The following is a description of a gene set: Any process that modulates the frequency, rate or extent of a process involved in the formation, arrangement of constituent parts, or disassembly of a chromosome. species: Mus musculus Mouse Gene Set: GOBP_REGULATION_OF_CHROMOSOME_ORGANIZATION, and this is the list of marker genes: Tal1, Spdl1, Smarca4, Mcph1, Mcrs1, Plk1, Myc, Baz1b, Ncapg, Prkcq, Cdc27, Rmi2, Becn1, Nabp2, Usp44, Pkib, Nat10, Mre11a, Ube2u, Smc2, Ncaph2, Map3k4, Smarcd2, Rnf4 (NCBI Gene Id 19822), Ino80d, Smarcc1, Tex14, Mapkapk5, Ankrd66, Dhx36, Setmar, Tacc3, Ino80b, Potefam3b, Anapc5, Cct4, Prpf4b, Tinf2, Tcp1, Nbn, Axin2, Wapl, Lig4 (ligase IV, DNA, ATP-dependent), Bmyc, Senp6, Cdk5rap2, Smc5, Terc, Smarcd3, Anapc11, Nek6, Tent4b, Naf1, Anapc4, Fbxo5, Sfpq, Arid1a, Smarcc2, Cdc6, Smc4, Knl1, Fshr, Mapk3, Riok2, Kat2b, Gnl3, Hnrnpu, Mos, Dync1li1, Parp1, Zw10, Sirt1, Actr5, Wnt3a, Nek2, Numa1, Hnrnpa2b1, Gch1 (NCBI Gene Id 14528), Ten1, Mad2l1bp, Slx1b, Ncaph, Pif1, Ddx11, Gen1, Cct7, H3f3b, Smg1, Klf4, Dpf2, Terf1, Ptges3, Ylpm1, Smarcb1, Ska1 (spindle and kinetochore associated complex subunit 1), Anapc1, Sgo2a, Dpf1, Incenp, Anapc2, Lcmt1, Anapc15, Atr, Smg6, Bcl7c, Smarca2, Arid2, Pot1a, Stn1, Cdc16, Phf10, Potefam3a, Slx4, Cct8, Dcp2, Hnrnpd (NCBI Gene Id 330135, heterogeneous nuclear ribonucleoprotein D), Xrcc3, Bub1b, Shcbp1l, Actr8, Aurkb, Zwint, Ncapd3, Bcl7b, Trappc12 (NCBI Gene Id 353082), Prap1, Ttk (NCBI Gene Id 22137), Trp53, Zwilch, Ruvbl1, Actl6a, Lmna, Xrcc5 (X-ray repair complementing defective repair in Chinese hamster cells 5), Tfpt, Ctnnb1, Naa10, Uchl5, Upf1, Cct2, Cenpv, Bub3, H3f3a, Spc25 (SPC25, NDC80 kinetochore complex component, homolog (S. cerevisiae)), Cdca8, Dkc1, Kntc1, Chfr, Rad21, Xrcc4, Ndc80, Nek7, Bub1, Ino80e, Ino80, Rad50, Nuf2, Fbxo4, Ik, Mad2l1, Actl6b, Smarca5, Sirt6, Tpr, Smg5, Mapk1, Ino80c, Mad1l1, Psmg2, Pbrm1, Anapc7, Ctc1, Actb (NCBI Gene Id 11476), Trip13, Slf2, Rtel1, Hecw2, Cdc23, Atrx, Mapk15, Ruvbl2, Nfrkb, Src, Ccnb1, Anapc15-ps, Nvl, Wdhd1, Brd7 (NCBI Gene Id 27017), Pml, Xrcc1, Tnks, Nsmce2, Cct5, Tnks2, Macroh2a1, Hmbox1, Zfp207, Cct3, Arhgap33os, Gnl3l, Rb1, Ncapd2, Ercc1, Recql4, Acd, Yy1, Ercc4, Dusp1, Smarcd1, Smarce1, Atm, Kat5, Cep192, Cct6a, Ccnb1-ps, Dpf3, Hdac8, Pnkp, Pot1b, Exosc10, Ska3, Slf1, Fen1, Birc5, Parn, Terf2ip, Haspin, Pinx1, Pcid2, Cdc20, Khdc3, Cdk1, Apc, Terf2, Ncapg2 (NCBI Gene Id 76044), Cit, Cenpe, Klhl22, Map2k7, Hnrnpc, Ube2c, Cdk2, Ppp1r10, Spc24, Bcl7a, Cul3, Wrap53